The following is a description of a gene set: studied in species Homo sapiens Skull asymmetry Human Gene Set: HP_SKULL_ASYMMETRY, and this is the list of marker genes: RAD21, FGFR2, TWIST1 (twist family bHLH transcription factor 1), MASP1, FTO, COLEC11, RSPRY1